The following is a description of a gene set: from publication Sartipy P, Loskutoff DJ (PMID 14530283) Human Gene Set: SARTIPY_BLUNTED_BY_INSULIN_RESISTANCE_DN Genes down-regulated in 3T3-L1 cells (adipocyte) by insulin but displayed blunted response to insulin the insulin resistant cells. We have employed microarray technology using RNA from normal 3T3-L1 adipocytes and from 3T3-L1 adipocytes made insulin-resistant by treatment with tumor necrosis factor-alpha to identify a new class of insulin-responsive genes. These genes continued to respond normally to insulin even though the adipocytes themselves were metabolically insulin-resistant, i.e. they displayed a significantly decreased rate of insulin-stimulated glucose uptake. Approximately genes/expressed sequence tags (ESTs) were screened. Of these, genes/ESTs were identified that became insulin-resistant as expected (e.g. Socs-3, junB, and matrix metalloproteinase-11). However, genes/ESTs continued to respond normally to insulin. Although some of these genes were previously shown to be regulated by insulin (e.g. Glut-1 and beta3-adrenergic receptor), other novel insulin-sensitive genes were also identified (e.g. Egr-1, epiregulin, Fra-1, and ABCA1). Real-time reverse transcription-PCR analysis confirmed the expression patterns of several of the differentially expressed genes. One gene that remained insulin-sensitive in the insulin-resistant adipocytes is the transcription factor Egr-1. Using an antisense strategy, we show that tissue factor and macrophage colony-stimulating factor, two cardiovascular risk factors, are downstream EGR-1 target genes in the adipocyte. Taken together, these data support the hypothesis that some signaling pathways remain insulin-sensitive in metabolically insulin-resistant adipocytes. These pathways may promote abnormal gene expression in hyperinsulinemic states like obesity and type II diabetes and thus may contribute to pathologies associated with these conditions. studied in species Mus musculus, and this is the list of marker genes: UBE2H, GADD45A, TRIB3, ACVR1, RARG, INTS9, CDK1, SESN1, DBP, NUPR1, PDK4, SGF29, MPDZ, RERE, MMP11, RALGDS, HERPUD1, CDKN1B